The following is a description of a gene set: species: Mus musculus Mouse Gene Set: GOBP_NEGATIVE_REGULATION_OF_DENDRITE_EXTENSION Any process that stops, prevents or reduces the frequency, rate or extent of dendrite extension., and this is the list of marker genes: Mecp2, Bcl11a, Ostn, Spag9, Atg16l1, Pten